Given this list of marker genes RNPEP, FDX1, SLC12A2, MZB1, NCAPD3, DERL3, CD300LF, SRM, NUSAP1, KIF13A, RAD18, BCL2A1, C1QBP, SLC66A1 (NCBI Gene Id 54896, solute carrier family 66 member 1), SMARCA2, ATF6, WDR6, TPX2, TNNT1, ZDHHC14, DNASE1L3, TOMM20, YDJC, PLEKHA8, CDKN3 (cyclin dependent kinase inhibitor 3), ATP6V1G2, SNHG12, MYBBP1A, AGRN, ALPK2, MCM10, ZC3H12D, TMED6, EVI2B, GSAP, CREG1, AFDN, BCAT1, ACKR2, TERB1, NLRP10, BCKDHB, ARHGEF12, CAMKMT, SPECC1L, SMCO3, MEIS3, TIMM21, NUDT12, BCAR3, HERC3, NDST1, SEPTIN6, MMD, SH3BGRL, E2F8, PROM1, TNFRSF18, TDRD3, RNASEL, SIRPA, MAN1C1, GPM6B, RBAK, FAM149A, ACSS1, DTYMK, SMYD2, AHR, RRM2, TSPAN15, SCEL, GM2A, TOR3A (NCBI Gene Id 64222), ABHD14A, LCMT1, NOBOX, IFT27, MKI67, ALG8, FSD2, PPFIBP2, CD9, PTGR1, SLC22A23, VWA7, RNF123, OOSP2, ITM2C, TXN, CSTPP1, PRC1, UBE2E3, SBF2, MRPL42, CDON, DTX3, GCSH, CAPN2, NEDD9, MED12L, TFPI, GSTT2 (glutathione S-transferase theta 2 (gene/pseudogene)), HPGDS, KNSTRN, FANCA (NCBI Gene Id 82952), TENM4, SIVA1, ELK3, SLC23A1, HPSE, ELL3, ST3GAL6, PLD4, APRT, MOCOS, SLC6A13 (NCBI Gene Id 6540), GPR34, AHCYL2, TXN2, CYP39A1, IL15RA, PLGRKT, FBXO9, DGLUCY, PTPN14, LGALS3BP, TK1, E2F7, GMNN, GPX7, STMN1, ADSS1, IRGQ, TARS2, GRIP2, GNG7, CD44 (CD44 molecule (IN blood group)), LDLRAD3, STIL, NOPCHAP1, TTYH1, BLOC1S2, E2F3, NSG2, ANLN, CEP15, PIK3R3, MTFR2, SLC46A3, CKS1B, ATP13A3, CIP2A, NOD1, NPR2, HLA-B, TSPAN31, CDCA5 (cell division cycle associated 5), CEP55, LTK, ZWILCH, PAOX, BLK, RGS11, ZUP1, POLR1E, OBI1, PC, NPRL3, TMEM100, IPO11, RRBP1 (NCBI Gene Id 6238), SAPCD1, CDH5, MGLL, NCAPG2, MXD1, EPS15 (NCBI Gene Id 2060), FGL2, NPM1, CLSTN1, MOB3C, AS3MT, MZT2B, CEP63, TMEM151B, NOP58 (NOP58 ribonucleoprotein), CHRNB1, WWOX, PBX4, SLC36A4, PLEKHA1, RMND1 (NCBI Gene Id 55005), SHCBP1, PMF1, MPEG1, PRDX6, ADORA3, ANXA9, here is a description of the gene set: Human Gene Set: GSE369_SOCS3_KO_VS_IFNG_KO_LIVER_DN Changes in mouse liver mRNA profiles following intraperitoneal cytokine injection. Either interferon-gamma-/-, albumin-cre(-) Socs3(w/fl) mice, or albumin-cre(+) Socs3(-/fl) mice were injected with either phosphate-buffered saline, interferon-gamma, or interfeukin-6, and livers taken after 4h. species: Homo sapiens Genes down-regulated in liver with knockouts of: SOCS3 versus IFNG. from publication Croker BA, Krebs DL, Zhang JG, Wormald S, Willson TA, Stanley EG, Robb L, Greenhalgh CJ, Förster I, Clausen BE, Nicola NA, Metcalf D, Hilton DJ, Roberts AW, Alexander WS (PMID 12754505)